Given this list of marker genes CENPP, LIMA1, TEDC1, EIF4E, MTHFD2, CCNE2 (cyclin E2), RFC3, CENPK, SLC1A4, TRAPPC1, MSH5, CEP55, RFC2 (NCBI Gene Id 5982), ZWILCH, IFT22, BTF3L4, SNRPA, DDIAS, EAF2, NDC80, TRMT10A, DNA2, BLVRB, SMC2, NDUFAB1, SELENOH, SLAMF7, HMCES, RAD51C, MYB, NUDT1, PSMA6, S1PR2, GINS1, POLA1, KIFAP3, EPPK1, EFNB1, SIVA1, TLCD2, COA7, RAB9A, MXD3, FXN, NANS, DMPK, ARL5A, EXOSC9, NUSAP1, FAM156A, NCAPG2, KIAA1217, NDUFB5, ATP5PO, GMNN, WNT5B, TOP1, PROK2, PALS2, CNTLN, SLC12A2, FH, USP6NL, GNB4, CENPN, POLE, ARHGAP11A, ATAD5, CCDC18, ATP6V0A1, HROB, DNASE1, TOP2A, EIF2A (NCBI Gene Id 83939), CENPA, STIL, CENPW, MAD2L1, ORC6, CKAP2L, TIMELESS (timeless circadian regulator), RNASEH2B, ASNS, TOX2, ASF1B, PTTG1, PARP8 (poly(ADP-ribose) polymerase family member 8, NCBI Gene Id 79668), COX6A1, PHF10, PPP2R2D, C8A, OIP5, SNRPD2, OTUB2, CIP2A, IGF2BP3, MCM7, GPATCH2L, CDKL1, ZRANB3, MASTL, RFC4, FKBP2, ATP5ME, SCRN2, RPS27L, PAM16, ADA, GPM6A, KNTC1, PLK4, FANCI, CENPU, SPC25, NCAPG, UBE2T, XPNPEP1, AURKB, ADHFE1, IMPDH2, PPP6C, RAD51AP1, PGPEP1, GINS3, ZBED3, PFN2, HMGN3, SHMT1, VPS29, CPSF6, SLAMF1, MMS22L, THOC7, TPI1, PRR11 (NCBI Gene Id 55771), VDAC3, IFT57, CCHCR1, SMAGP, CPNE5, WSB2, NCAPH, CHAC1, SERPINF1, SLC25A33, ALDH9A1, UXS1, MCM10, PMF1, GNG12, RBBP8, EIF1AX, SH3BGRL2, ANAPC15, RRM1, CISD1, PCLAF, APOC2, AARS1, IRAK1BP1, SNTG2, KIF20A, GNAL, SLCO4A1, RGCC, POLR3K, GINS2, AKIRIN2, KIF18B, USP24, CDKN2C, PLPP1, MCM3, DBF4 (NCBI Gene Id 10926), KIF4A, FANCD2, TLX3, CELSR1, TMEM256, ASRGL1, XRCC1, PTRHD1, TSNAXIP1, SCN11A, PTGR1, SLC25A40, PRIM2, TCF19, RAPH1, ESCO2 (establishment of sister chromatid cohesion N-acetyltransferase 2), CS, SYCE2, LIG1, ARHGAP29, NDUFC2, MAGED1, CENPL, ECT2, LSS, BUB1B, here is a description of the gene set: The transcription factor FoxP3 partakes dominantly in the specification and function of FoxP3+ CD4+ T regulatory cells (Tregs), but is neither strictly necessary nor sufficient to determine the characteristic Treg transcriptional signature. Computational network inference and experimental testing assessed the contribution of several other transcription factors (TFs). Enforced expression of Helios or Xbp1 elicited specific signatures, but Eos, Irf4, Satb1, Lef1 and Gata1 elicited exactly the same outcome, synergizing with FoxP3 to activate most of the Treg signature, including key TFs, and enhancing FoxP3 occupancy at its genomic targets. Conversely, the Treg signature was robust to inactivation of any single cofactor. A redundant genetic switch thus locks-in the Treg phenotype, a model which accounts for several aspects of Treg physiology, differentiation and stability. species: Homo sapiens from publication Fu W, Ergun A, Lu T, Hill JA, Haxhinasto S, Fassett MS, Gazit R, Adoro S, Glimcher L, Chan S, Kastner P, Rossi D, Collins JJ, Mathis D, Benoist C (PMID 22961053) Human Gene Set: GSE40274_CTRL_VS_FOXP3_TRANSDUCED_ACTIVATED_CD4_TCELL_UP Genes up-regulated in CD4 T conv: control versus over-expression of FOXP3.